Given this list of marker genes Npy, Tusc2, Lalba, App, Tnfrsf14, Lyz1 (lysozyme 1), Il12b, Tlr9, Gsdmd, Defa29 (NCBI Gene Id 93795), Tac1, Defa42, Trem2, Naip5, Hmgb2, Defa2, Peli3, Defb1, Trem1, Defa38, Adgrb1, H2bc12, Hamp2, Optn, Elane (NCBI Gene Id 50701), Defb39, Defb6, Drosha, Defb9, Aqp1, Tlr4, Rpl30, Serpine1, Hamp, Defa35 (defensin, alpha, 35), Rnase6, Defb12, Il17f, Nod1, Slc11a1, Iigp1, Defa34, F2rl1, Nfkbiz, Cd4, Defb19, Igtp, Defa23, Defa5, Defb20, Cxcl5 (NCBI Gene Id 29874), Il23a, Mpeg1, Defa30, Pfpl, Pycard, Tslp, Defa21, Mr1, Il17a, Cst11, Galp, Defb40, Defb11, Defa40, AY761185, Defb4, Rarres2, Defa28, Cd160, Defb38, Dmbt1, Defa20, Reg3g, Adm, Camp, Trem3, B2m, Il22ra1, Romo1, Defb42, Defa25, Defb2 (NCBI Gene Id 13215), Lyz3, H2bc21, Defa22, Lbp, Reg3b, Lyz2, Bpi, Defa26, Defa41, Defa24, Defb37, Defa37, Irgm2, Prkd1, Defb10, Defa3, Vip, Irgm1, Defa17, Ltf, Mmp7, Defb21, Defb8 (NCBI Gene Id 244334), Dao, Tfeb, Ssc5d, Defa39, Rps19, Ighm, Defb22, Casp1, F2, Ctsg, Chga, Lypd8, Umod, Defa31, here is a description of the gene set: Reactions triggered in response to the presence of a Gram-negative bacterium that act to protect the cell or organism. species: Mus musculus Mouse Gene Set: GOBP_DEFENSE_RESPONSE_TO_GRAM_NEGATIVE_BACTERIUM